The following is a description of a gene set: Genes predicted to be targets of miRBase v22 microRNA mmu_miR_7049_3p in miRDB v6.0 with MirTarget v4 prediction scores > 80 (high confidence targets). Mouse Gene Set: MIR_7049_3P studied in species Mus musculus from publication Chen Y, Wang X (PMID 31504780), and this is the list of marker genes: Stim1, Paip1, Mbnl1, Ano3, Casp9, Sema4g, Srpk1, Kpna6, Chrm1, Rxrb, Zfand5, Nptxr, Htt, Vkorc1, Gpn2 (NCBI Gene Id 97192), Camkk2, Mknk1, Thsd1, Tjap1, Adamtsl1, Coq10a, Lrfn4, Ip6k3, Klhl28, Ube2g1, Csmd2, Gmppa, Etl4, Ackr3, Sfrp1, Aif1l, Pkp1, Tmem229b, Scn2b (sodium channel, voltage-gated, type II, beta), Slc66a2, Cpeb1, Map3k3, Zbtb41, Iqsec2, Get4, Tsc1, Camk1d, Rims2, Cep112, Il17ra, Aff4, Cdc42ep4, Baiap2 (brain-specific angiogenesis inhibitor 1-associated protein 2), P2rx3, Gnaq, Ets2, Slx4ip, Fgf14, Mrm1, Slc25a10, Avpi1, Ankrd13a, Gata2, Fhip1b, Epb41l1, Egln3 (NCBI Gene Id 72158), Usp32, Ngef, Homer1, Ppm1l, Snx6, Lin9, Mapk7, Cds2 (CDP-diacylglycerol synthase 2), Dagla, Rnf34, Abca2, Ttc39a, B3gat1, Cic, Gpa33, Chst11, Slc2a4, Lrtm2, Tgfbi, Rad54l